The following is a description of a gene set: from publication Unterman A, Zhao AY, Neumark N, Schupp JC, Ahangari F, Cosme C Jr, Sharma P, Flint J, Stein Y, Ryu C, Ishikawa G, Sumida TS, Gomez JL, Herazo-Maya JD, Dela Cruz CS, Herzog EL, Kaminski N (PMID 38717443) studied in species Homo sapiens Thirty-eight PBMC samples from 25 patients with IPF and 13 matched controls yielded 149,564 cells that segregated into 23 subpopulations. Classical monocytes were increased in progressive and stable IPF compared to controls (32.1%, 25.2%, 17.9%, respectively, p<0.05). Total lymphocytes were decreased in IPF vs controls, and in progressive vs stable IPF (52.6% vs 62.6%, p=0.035). Tregs were increased in progressive vs stable IPF (1.8% vs 1.1% of all PBMC, p=0.007), although not different than controls, and may be associated with decreased survival (P=0.009 in Kaplan-Meier analysis; P=0.069 after adjusting for age, sex, and baseline FVC). Flow cytometry analysis confirmed this finding in an independent cohort of IPF patients. Fraction of Tregs out of all T cells was also increased in two cohorts of lung scRNA-seq. CCL22 and CCL18, ligands for CCR4 and CCR8 Treg chemotaxis receptors, were increased in IPF. The single-cell atlas of the peripheral immune system in IPF, reveals an outcome-predictive increase in classical monocytes and Tregs, as well as evidence for a lung-blood immune recruitment axis involving CCL7 (for classical monocytes) and CCL18/CCL22 (for Tregs). (From Abstract) Human Gene Set: UNTERMAN_PROGRESSIVE_VS_STABLE_IPF_NK_CELL_DN Genes downregulated in NK cells from Progressive Idiopathic Pulmonary Fibrosis Patients vs. Stable Non-Progressors, and this is the list of marker genes: TRAC, HLA-DPA1, IL32, HLA-DRB5, NFKBIA, TKTL1, CD74, KLRC1, HLA-DRB1, CD52, HLA-DPB1, GZMK